Given this list of marker genes GCK, MEN1, HNF1A, PAX4, GLUD1, KMT2D, KLF11, MPI, NEUROD1, KDM6A, HNF4A, INSR, APPL1, PDX1, CEL, HADH, CDKN1B, UCP2, BLK, SLC16A1, INS, ABCC8, FOCAD, TRMT10A, KCNJ11, YY1, MAFA, here is a description of the gene set: Hyperinsulinemic hypoglycemia Human Gene Set: HP_HYPERINSULINEMIC_HYPOGLYCEMIA species: Homo sapiens An increased concentration of insulin combined with a decreased concentration of glucose in the blood.